The following is a description of a gene set: TCR-PLCG-ITPR signaling pathway. Pathway ID: N01106. Pathway type: Reference. Pathway class: nt06528 Calcium signaling. Human Gene Set: KEGG_MEDICUS_REFERENCE_TCR_PLCG_ITPR_SIGNALING_PATHWAY studied in species Homo sapiens Pathway Definition from KEGG: (TCR+CD3+CD4) -> (LCK,FYN,ZAP70) -> (SLP76+GADS+LAT+VAV) -> PLCG -> IP3 -> ITPR -> Ca2+(cyto), and this is the list of marker genes: CD3D, VAV2, ITPR2, CD3E, CD247, GRAP2, ZAP70, CD4, PLCG2, LCK, LAT, PLCG1, ITPR3, ITPR1, VAV1, LCP2, VAV3, FYN, CD3G